The following is a description of a gene set: from publication Fiorentini S, Riboldi E, Facchetti F, Avolio M, Fabbri M, Tosti G, Becker PD, Guzman CA, Sozzani S, Caruso A (PMID 18310327) We used microarrays to detail the global program of gene expression underlying the effect of p17 on human plasmacytoid dendritic cells and was compared to CpG profile. Genes up-regulated in plasmacytoid dendritic cells treated with IL3: HIV matrix protein p17 versus CpG. Human Gene Set: GSE10147_IL3_AND_HIVP17_VS_IL3_AND_CPG_STIM_PDC_UP studied in species Homo sapiens, and this is the list of marker genes: MAP3K6, KLHL23, VARS1, RHOU, RSPO1, FAM3C, COLEC11, GDPD3, WNT16, UBASH3A, RPL41, KANK1, SDHA, NEK11, H1-6, BTLA, ABTB3, MED29, MT-CYB, ANXA7, SGCZ, SIAH2, DOK2, GALNT10, GTF2H4, RPS26, CERK (ceramide kinase), PDLIM1, KLK12, ENPEP, IGF2-AS, ECM1, LRRC7, TTYH3, CIDEC, DCBLD1, FOXH1, DCLRE1A, USP26, PRDM11, SYPL2, F7, DMPK, TLE1, PRSS42P, TASP1, GIMAP3P, FNDC3B, TEX14, LRRC56, NCAPD2, KLK11, ERN2, NOL4 (nucleolar protein 4), REEP2, MUC6, HDHD5, MORN3, CNBP, KRT76, H4C14, NPW, RPL36A, KRTCAP2, GPR162, PYHIN1, LAMB2, COX6B2, KIF21A (NCBI Gene Id 80819), PSCA, NR4A2, BUB1B, ACTG2, HOPX, ANKIB1, PSMC3, SP6, RTN2, PLEKHG4, SOWAHC, ADAMTS12, KNCN (NCBI Gene Id 148930), TRIM34, GTSF1L, CYB561, PLCH2, COMMD7, CCL8, IL17B, PPP1R3C, FBLN1 (NCBI Gene Id 2192), SH3BP2 (SH3 domain binding protein 2), ACTBL2, ARMCX1, AGPAT4, TNFSF14, LRRC18, PKD1L1 (NCBI Gene Id 168507), GRIP2, C11orf68, SYNDIG1L, NLGN2 (NCBI Gene Id 57555), CPM, DBF4, PLBD1, EPHB3, BRD9, EFCC1, HDAC11, PLD5, CCDC81, NXPH3, CCDC120, ST6GALNAC5, JAGN1, WWTR1, PDK4, NLRP3, UBTD1, CIMAP1D, ARL6IP5, BTNL10P, GPR6, DPF3, CLEC18A, EPO, SYCN, RHBDF1, BMP6, ALS2CL, HERPUD1, DUSP13B, A3GALT2, DLL4, CHRND, MERTK, MRAS, OXR1, SCARA5, KCNJ16, GTF2A1L, TMC5, MAPK4, MNS1, CLEC2D, CHEK2, PIH1D2, ACACB, JSRP1, TOGARAM2, FBH1, CUZD1, CYP2R1, RUNX2